The following is a description of a gene set: Human Gene Set: GAO_SMALL_INTESTINE_24W_C3_ENTEROCYTE_PROGENITOR_SUBTYPE_1 species: Homo sapiens from publication Gao S, Yan L, Wang R, Li J, Yong J, Zhou X, Wei Y, Wu X, Wang X, Fan X, Yan J, Zhi X, Gao Y, Guo H, Jin X, Wang W, Mao Y, Wang F, Wen L, Fu W, Ge H, Qiao J, Tang F (PMID 29802404), and this is the list of marker genes: C17orf78, AADAC, PCYOX1L (prenylcysteine oxidase 1 like), CA3, ADH1C, TSPAN8, STARD13-AS, SLC35C2, SLC35A4, BOP1, SLC51B, POF1B, PRR15, ZNF586, MATN1-AS1, SCARNA2, GCNT1 (NCBI Gene Id 2650), CYP2J2, CDK5, TATDN1, CD24, PLEK2, CHCHD10, DNAJC14, GSTA1, HDDC3, PRR15L, CCL25, FCSK, TTR (NCBI Gene Id 7276), CAMKV, PIGH, PEX14, ENPP4, MGST1, NR5A2, RNASE6, GSTA2, ATP2A1, DRG2, DUS3L, SLC2A1, KIF26B, COMMD1, CASC2, DMBT1, ST20, VPS26B